Given this list of marker genes PPP3CA, ADISSP, ITGB3BP, ARF3, GMPPB, PBXIP1, DUSP3, CALY, FNDC9, SIX1, SOX12, LINC01973 (NCBI Gene Id 400624), CELF6, AP3M2 (NCBI Gene Id 10947), ARG2, CRYZL1, CAMK2A, SHANK1, C10orf67, MAPK10, NCDN, TNKS1BP1, CYRIA, IL1A (interleukin 1 alpha), KCNN2, NUDT3, CFAP100, TFAP2B, CRYGD, OGT, AARSD1, PARP8, EIF2B2, MAPRE3, JUNB, CNIH2, RUNDC1, PNMA8A, RFX4, GNB2, KIF9, GPR162, KLHDC8B, KATNAL1, POLL, DPCD, ARRDC4, SYT6, TRMT9B, LARGE2, NTN3, IER5L, C14orf132, PIN1, FXYD7, ILF3-DT, FEV, YWHAQ, LPIN2, TMED10, E2F1, FOXH1, PLPPR1, PCSK1N, ANK2, ZNF24 (NCBI Gene Id 7744), CWC25, PTK2B (NCBI Gene Id 5748), PPP1R17, KATNAL2, LINC01138, YWHAZ, FEZF2, SMG7, RIN1 (NCBI Gene Id 9610), MINK1 (NCBI Gene Id 50488), CCDC181, DAAM1, IL21, PPM1E, CFAP53, TP53BP1, FXYD1, TMEM107, MPPED2, STX18, LRRTM3, TIMP4, SLC39A12, GRIN2D (glutamate ionotropic receptor NMDA type subunit 2D), STXBP3, NNAT, DYNC2I2, DDR1, NOS1, ITSN1, PPP1R21, STOML2 (NCBI Gene Id 30968), SEMA4B, CHST8, BTBD3, ELAPOR1, FXYD6, ILF3, CACNB2, SLC8A3, TAF6L, SENP1, KLHL18, RRAGD, PHF21A, HPCAL4, MET, ORAI3, KCNIP4 (potassium voltage-gated channel interacting protein 4), PAK6, NFATC4, NLGN3, here is a description of the gene set: Comprehensive identification of all functional elements encoded in the human genome is a fundamental need in biomedical research. Here, we present a comparative analysis of the human, mouse, rat and dog genomes to create a systematic catalogue of common regulatory motifs in promoters and 3' untranslated regions (3' UTRs). The promoter analysis yields 174 candidate motifs, including most previously known transcription-factor binding sites and 105 new motifs. The 3'-UTR analysis yields 106 motifs likely to be involved in post-transcriptional regulation. Nearly one-half are associated with microRNAs (miRNAs), leading to the discovery of many new miRNA genes and their likely target genes. Our results suggest that previous estimates of the number of human miRNA genes were low, and that miRNAs regulate at least 20% of human genes. The overall results provide a systematic view of gene regulation in the human, which will be refined as additional mammalian genomes become available. Human Gene Set: RYTGCNWTGGNR_UNKNOWN from publication Xie X, Lu J, Kulbokas EJ, Golub TR, Mootha V, Lindblad-Toh K, Lander ES, Kellis M (PMID 15735639) Genes having at least one occurrence of the highly conserved motif M87 RYTGCNWTGGNR in the regions spanning 4 kb centered on their transcription starting sites. The motif does not match any known transcription factor binding site. species: Homo sapiens